The following is a description of a gene set: Human Gene Set: GOBP_L_LEUCINE_IMPORT_ACROSS_PLASMA_MEMBRANE The directed movement of L-leucine from outside of a cell, across the plasma membrane and into the cytosol. studied in species Homo sapiens, and this is the list of marker genes: SLC3A2, SLC7A5, SLC7A8, SLC43A2, SLC43A1